The following is a description of a gene set: species: Mus musculus electronically inferred by orthology from the curated human pathway Reactome Pathway: Processing of Intronless Pre-mRNAs This event has been computationally inferred from an event that has been demonstrated in another species.<p>The inference is based on the homology mapping from PANTHER. Briefly, reactions for which all involved PhysicalEntities (in input, output and catalyst) have a mapped orthologue/paralogue (for complexes at least 75% of components must have a mapping) are inferred to the other species. part of: Processing of Capped Intronless Pre-mRNA, and this is the list of marker genes: Wdr33, Papola (poly (A) polymerase alpha), Cpsf3, Fip1l1, Clp1, Cpsf1